The following is a description of a gene set: Mouse Gene Set: GOBP_CELL_MORPHOGENESIS_INVOLVED_IN_NEURON_DIFFERENTIATION The process in which the structures of a neuron are generated and organized. This process occurs while the initially relatively unspecialized cell is acquiring the specialized features of a neuron. studied in species Mus musculus, and this is the list of marker genes: Lhx4, Metrn, Abl1, Skor2, Ep300, Psen1, Camk2b, Arhgef28, Gbx1, Numbl, Lhx3, D130043K22Rik, Myo5b, Myh10, Ankrd27, Isl1, Celsr2, Ntrk1, Ust, Sgk1, Nfib (NCBI Gene Id 77183), Nefm, Chodl, Dvl1, Nrp2, Lhx9, Mef2c, Flrt3, Itgb1, Chl1, Pmp22, Otx2, Gdf7, Ptprq, Shank3, Cdh11, Wls, Tnn, Ache (acetylcholinesterase), Fam168b, Mag, Mapk8ip2, Mir9-1, Pip5k1c, Lmx1a, Ctnnd2, Igf1r, Notch1, Triobp, Mapk8ip3, Ophn1, Shtn1, Cnp, Sh3glb1, Sema3b, Gla, Epha10, Unc5d, Rnf6, Anapc2, Lama5, Plxnc1, Ndn, Numb, Ark2c, Mir200a, Fgf8, Ttl, Pla2g10, Ext1, Bcl11b, Ankrd24 (ankyrin repeat domain 24), Tecta, Slitrk6, Raph1, Tbc1d24, Emb, Lama3, B4galt5, Dip2b, Syngap1, Slitrk5, Scn11a, Tsku, Dbnl, Dst, Itga4, Crabp2, Nova2 (NCBI Gene Id 434131), Gdi1, Opa1, Epha7, Snap91, Celsr3, Mir200b, Bmpr1b, Enah, Plxnd1, Sema3c, Fgfr2, Fbxo45, Rufy3, Dip2a, Actg1, Ulk1, Slc1a3, Cntn2, Epha3, Eif2b2, Sema6b (sema domain, transmembrane domain (TM), and cytoplasmic domain, (semaphorin) 6B), Arhgap44, Zdhhc17, Tlx2, Actb, Efna4, Braf, Cntn1, Rgma (NCBI Gene Id 244058), Arhgap35, Sema4a, Golga2, Cyfip2, Lrp1, Reln, Mapt, Ryk, Abi3bp (ABI family member 3 binding protein), Gli3, Cd2ap, Ptprj, Kifbp (kinesin family binding protein), Adcy1, Brsk2, Rpl4, Spr (NCBI Gene Id 20751), Adam10, Nlgn1, Pax6, Myo7a, Gap43 (NCBI Gene Id 14432), Cux2, Fzd4, Sema7a, Chrna7, Shh, Atg16l1, Stk11, Slc11a2, Dab1, Rap2a, Cck, Rere, Aplp2, Trpc5, Vcl, Slit3, Ripor2, Bcl2, Map6, Nell2, Acte1, Top2b, Gdnf, Tgfb2, Cfap418, Slit2, Sema4c, Bdnf, Abi2, Ptprv, Prickle1, Ube3a, Vangl2, Dnm2, Wdpcp, Zic2, Grin1, Nfasc, Trim46, Fat3, Pou4f3, Sec24b, Mir9-3, Smn1, Btbd3, Atp7a, Sod1, Matn2, Pak2, Ist1, Nr4a2 (nuclear receptor subfamily 4, group A, member 2), Ttc8, Dlg4, Atp2b2, Kidins220, Plppr4 (phospholipid phosphatase related 4), Mgll, Tnfrsf12a, Vldlr, Stmn1, Apbb2, Spart, Flot1, Strc, Map1a, Arhgap32, Mir200c, Abitram, Nrp1, Kif1a, Lpar3, Akap5, Nefl, Kif13b, Fgf13, Ttc3, Map1s, Ntn3, Wnt5a, Diaph2, Bbs1, Slitrk4, Map2k2, Cntn5, Clrn2, Rac3, Tpbg, Arx, Ngf, Nin, Kel, Chn1, B4gat1, Nrcam (neuronal cell adhesion molecule), Bhlhe22, Notch3, Apc, Cdkl3, B3gnt2, Ulk2, Neurog2, Rock2, Mapk8 (NCBI Gene Id 26419), Ntrk3, Rnd2, Adnp, Parp6, Hoxa1, Csf1r, Unc5b, Map2k1, Fxn, Atp8a2, Fyn, Pcdhac2, Boc, Srcin1, Mfn1, Cdh23 (NCBI Gene Id 67650), Vax2, Hdac6, Omg, Rtn4, Igfals, Macf1, Slc30a1, Ush1c, Trio, Trak2, Wnt7b, Smo, Plxna4, Sema3g, Nfix, Vax1, Id2, Wasl, Nptx1, Olfm1, App, Edn2, Arhgef25, Uchl1, Robo2, Mir376a, Met, Ywhah, Prex2, Baiap2, Rbfox2, Tmem106b, Megf8, Artn (NCBI Gene Id 11876), Ptch1, Rab8a, Ptprf, Ss18l1, Flrt2, L1cam, Ift56, Ngfr, Ncam1, Auts2, Lrrc4c, Arc, Spast, Trpv2, Efnb2 (NCBI Gene Id 13642), Camk2a, Dcc, Ndp, Lzts3, Lzts1, Sema4g, Efna2, Ilk, Sult4a1, Llgl1 (LLGL1 scribble cell polarity complex component), Cntnap2, Cdk5r1, Atoh7, Map3k13, Picalm, Apbb1, Gm2990, C9orf72, Tet1, Adgrb3, Usp33, Mfn2, Etv1, Sema3d, Vasp, Plxnb2, Neo1, Tctn1, Rac1, Smad4, Eef2k, Lgi1, Stk25, Robo1 (NCBI Gene Id 436378), Cacna1a, Hexa, Hecw1, Ptpro, Caprin2, Myo3b, Chrnb2, Tsc2, Bcl11a (BCL11 transcription factor A), Bsg, Ephb6, Pqbp1, Evl, Ephb1, Shank1, Myo3a, Atoh1, Pafah1b1, Usp9x, Pcdh15, Cxcr4, Lmo4, Abi3, Vegfa, Ank3, Hecw2, Dnm1l, Rpl24, Ythdf1, Unc5a, Efnb3, Ctnna2, Kifc2, Afdn, Cit, Aplp1, Efna3, Amigo1, Shox2, Smurf1, Nedd4, Lamc3, Lhx2, Or10a4, Ppfia2, Foxp1 (forkhead box P1), Slc25a46, Zdhhc15 (NCBI Gene Id 68086), Ptprd, Col25a1, Cdc42, Pdlim5 (PDZ and LIM domain 5), Ngef, Zeb2, Sarm1, Cdh1, Phactr1, Rab21, Nexn, Gata3, Cc2d1a, Scn1b, Dpysl5, Sema5b, Fbxo31, Dact1, Ptn, Arhgap4, Pak1, B4galt6, Tbr1, Ntng1, Lamc2, Foxb1, Npr2, Sema3e (NCBI Gene Id 330043, sema domain, immunoglobulin domain (Ig), short basic domain, secreted, (semaphorin) 3E), Prkg1, Nedd4l, Dlx5, Pten, Dhx36, Tubb2b, Cacna1f, Adam17, Kif5b, Tbcd, Dclk1, Tiam1, Ntng2, Lmtk2, Dscaml1, Tprn, Gas1, Draxin (NCBI Gene Id 70433), Sema4d, Ptprm, Mycbp2, Megf9 (NCBI Gene Id 71014), Ntrk2, Mir124a-1, Xlr3b, Drd2, Hoxa2, Id1, Marcks, Prmt3, Efna1, Actbl2, Or8a1b (olfactory receptor family 8 subfamily A member 1B), Ifrd1, Sema3a, Dag1, Fezf1, Atg7, Gli2, Ccr5, Alcam, Plxnb3, Mir124a-2, Slitrk2, Ssna1, Mir9-2 (microRNA 9-2), Foxd1, Cdk5r2, Hes1, Kif5c, Barhl2, Sema6a, Pls1, Cobl, Cttn, Szt2, Efna5, Cfl1, Efnb1, Edn3, Kalrn, Il1rapl1, Ptprs, Afg3l2, Cul7, Dbn1, Cdh2, Ednra, Cdhr1, Sema5a, Pak3, Mir96, Phox2b, Unk, Kndc1, Spg21, Lamb2, Cntnap1, Nog, Disc1, Pias2, Nptn, Klf7, Rabl2, Nsmf, Trak1, Gfra3, Map2, Nrn1, Dcx, Gprin3, Adarb1, Sin3a, Rapgef2, Nfatc4, Ptprz1, Ephb2, Thy1, Apoe, Mnx1, Actr3, Gsk3b, Cyfip1, Ntn4, Mef2a, Ntn5, Tnik, Eif4g2, Whrn, Ndel1, Creb1, Lrp8, Hprt1, Rtn4r, Wnt3, Dixdc1, Grk1, Ephb3, Plxnb1, Rtn4rl1, Wnt7a, Dcdc2a, Cux1, Abl2, Mt3 (NCBI Gene Id 17751), Slc9a6, Skil, Wdr36, Ppp1r9a, Rab10 (RAB10, member RAS oncogene family), Pdzd7, Pitpna, Clasp2, Obsl1, Grip1, Tubb3, Twf2, Drgx, Bmpr2, Ablim1, Foxg1, Ece1, Prdm8, Atl1, Limk1, Pou4f2, Lrp4, Lrp2, Rb1, Sdc2, Nefh, Nkx2-1, Mark2, Elavl4, Dtnbp1, Dscam, Wnt3a, Mink1, Diaph1, Ppp3ca, Scrib, Crppa, Gorasp1, Lamb1, Fn1, Slitrk3, Ntn1, Grxcr1, Sema4f, Adcy10, Pou3f2, Cabp4, Septin7 (septin 7), Prtg, Cxcl12, Runx3, Nr2e1, Tanc2, Dnm3, Dock10, Zfyve27, Sptbn4, Mypn, Arhgap33, Myot, Sema4b, Gbx2, Stxbp5, Epha6, Evx1, Igf2bp1, Nr4a3, Etv4, Dubr, Ptk2, Sema3f, Lgr4, Slit1, Tnr, Fgfr3, Ret, Snap25, Clrn1, Xk, Epha4, Trpc6, Nkx6-1, Map1b, Slitrk1, Stau2, Mfsd2a, Kif5a, Fstl4, Islr2, Sipa1l1, Nlgn3, Tbce, Tiam2, Kif21a, Nkx2-9, Cckar, Grcc10, Unc5c, Taok2, Egr2, Lamb3, Epha5, Neurog3, Prkca (protein kinase C, alpha), Fezf2, Nherf1, Plxna3, Lrrk2, Stxbp1, Sema6c, Agrn, Erbb2, Ntf3, Cdh4, Abi1, Lama2 (NCBI Gene Id 215870), Lhx1, Ptprh, Bmp7, Itpka, Lhfpl5, Nectin1, Vim, Sema6d, Fzd3, Clic5, Cntn6, Ptpn11, Cdkl5, Caprin1, Golga4, Fbxw8, Cdk5, Edn1, Isl2, Robo3, Lama1, Lamc1, Cask, Zfp365, Bhlhb9, Mbp, Grxcr2, Als2, Actr2, Farp1, Chrna3, Srf, Rest, Wdr47, Dock7, Spg11, Epha8, Rab3a, Brsk1, Nrdc